Given this list of marker genes Shh, Pdgfa, Wnt6, Smo, Bmp4, here is a description of the gene set: Any process that results in the transfer of information from an epithelial cell to a mesenchymal cell where it is interpreted. studied in species Mus musculus Mouse Gene Set: GOBP_EPITHELIAL_MESENCHYMAL_CELL_SIGNALING